Given this list of marker genes DGKQ, GNB3, PNLIP, CPT1A, DGKK, GPAT3, LDLR, PNPLA2, CETP, DGKZ, APOF, AGPAT2, MGLL, CAV1, PNPLA1, PLA2G4A (NCBI Gene Id 5321), DAGLA, FAAH, PLAAT3, GPX1, PNPLA3, MIR29B1, MOGAT3, SLC27A1 (NCBI Gene Id 376497), SLC27A5, ABHD5, APOB, PNPLA5, APOA5, CNEP1R1 (CTD nuclear envelope phosphatase 1 regulatory subunit 1), LIPA, CIDEB (cell death inducing DFFA like effector b), CIDEC, SORL1, DGAT2L6, LIPC, LPIN2, SLC22A4, DAGLB, PNLIPRP1, ABHD2, MOGAT1, ABHD16B, PLA2G15, AWAT2, DGKH, NR1H2, LIPG, TBL1XR1, GPR82, GK, DGAT2, MBOAT7, PNLIPRP3, MOGAT2, PIK3CG, SCARB1, DGKE, GPIHBP1, SNCA, APOC3, GPAM, SIK1, PCSK9, LPIN3, SREBF1, LPL, MTTP, LIPE, FBXW7, AVIL, APOBEC1, ABHD6, SEL1L, APOH (apolipoprotein H), INSIG2, APOC1, MIR548P, MFSD2A, PLIN5, APOBR, PLB1, TNXB, INSIG1, LMF1, GK2, ATG14, PNLIPRP2, LIPF, PLCE1, MIR30C1, AADAC, GK5, GPAT2, ABHD12B, DGKB (NCBI Gene Id 1607), GPAT4, SIRT1, CAV3, C3, DGKA, DGKI, GPLD1, PCK2, DGKG, TMX1 (NCBI Gene Id 81542), NKX2-3, THRSP, KAT5, ABHD12, CAT, ABHD16A, CTDNEP1, APOA4, MIR192 (NCBI Gene Id 406967), APOC2, APOE, CPS1, TMEM68, FUT1, AGPAT5, DGKD, DGAT1, PTPN11 (protein tyrosine phosphatase non-receptor type 11), ACSL1, NR1H3, DDHD2, LPIN1, APOA2, AGMO, LPGAT1, SERPINA12 (NCBI Gene Id 145264), PGS1, PCK1, G6PC1, PNPLA4, PANK2, LYPLA2, FITM2, here is a description of the gene set: Human Gene Set: GOBP_NEUTRAL_LIPID_METABOLIC_PROCESS The chemical reactions and pathways involving neutral lipids, lipids only soluble in solvents of very low polarity. studied in species Homo sapiens